The following is a description of a gene set: Mouse Gene Set: OGT_TARGET_GENES from publication Yevshin I, Sharipov R, Kolmykov S, Kondrakhin Y, Kolpakov F (PMID 30445619) Genes containing one or more binding sites for (Ogt) in their promoter regions (TSS -1000,+100 bp) as identified by GTRD version 20.06 ChIP-seq harmonization. species: Mus musculus, and this is the list of marker genes: Egr4, Nup50, Zbtb4, Kif26a, Gm20605, Gm7008, Farsa, Zfp467, Cers6, Natd1, Rtkn, Prps1l3, Fam167a, Srpra, Hspa1l, Tubgcp4, E130311K13Rik, 1110065P20Rik, Phyh, Foxp4, Tmem86a, Tmem74b, Lrp12, Cbarp (NCBI Gene Id 50491), Rpia, Arl4a, Cad, Ldlrad4, Rfx4, Fam178b, Mocs3, Tram1, Ddx17, Clcn2, Bsg, Mrpl2, Gtf2f2, Nlrp5-ps, Tmem123, Trrap, Mms19, 2810004N23Rik, Hmgn1, Ppp1r13l, Dis3l2, Dusp12, Foxf1, mt-Tn, Fhl4, Fcho1, Nat8l, Npl (N-acetylneuraminate pyruvate lyase), Plaat5, Chmp6, Plekhm3, Nol4l, Pacc1, Spopl, Slc25a29, Gatad2a, Asrgl1, Gab1, Crocc, 2300009A05Rik, Anp32b, Tmed4, Smc6, Sh2b3, Itga2b, Cdiptos, Lypd6, Tbrg1, Ndufab1 (NCBI Gene Id 72270), 2810429I04Rik, Trp53bp2, Cxxc5, Gpr68, Ube2g2, Ankrd46, Mapkapk2, Tpt1, A930001C03Rik, Rnf216, Mageb3, Rsrp1, Gpatch11, Lsm14b, Dpp9, Ccdc47, Amotl2, Strip2, Atp6v1f, Bag3, Gm15706, Tug1, Csnk1g1, Adamts20, Stat5a, Ccdc136, Serpine2, Cnppd1, Atp5f1d, Pias3, Tbc1d5, Rrm1, Aktip, Gm10171, Mrps33, Rffl, Depdc7, Nelfe, Celf6, Zfp326, Ptpa (protein phosphatase 2 protein activator), A730035I17Rik, Cpsf4, Gpc4, Ptcd1, Relb, Prkab2, Arhgap35, Chordc1, Gm19569 (predicted gene, 19569), Traf3ip1, Tmem198, Gm27011 (NCBI Gene Id 115486886), Cyb561d1, Crat, Gm9889, Kndc1, Samhd1, Ccnt2, Pik3c2b, Gna15, BC005624, Rere, Dusp5, Tmem237, Tnip1, Plch1, Sar1a, Anapc11, Zfp646, Mtss2, Abcg2, Rapgef6, Wee1, Gm6288 (NCBI Gene Id 635291, predicted gene 6288), Crmp1 (collapsin response mediator protein 1), Ggnbp2, Mapkapk5, Atp5mc3, Wac, Sucla2, Kif7, Lpar3 (lysophosphatidic acid receptor 3), Cpeb3, H19, Naa16, Ubxn7, Atp6v1c1, Denr, Pcgf1, Dbil5, Zfp712, D2hgdh, Sptlc2, Reln, Pgap4, Carhsp1, Mmgt2, Tent2, Ywhae, N4bp3, Kcnn2, Kat6a, Tex264, Tbc1d20, Foxo6, Sp6, Cbx8, Oxnad1, Hectd4, Mipol1, Syncrip, Pkp1, 4930449I04Rik, Thap6, Hikeshi, Cnih4, Alkbh5, Zfp703, Eef2k, Mael, Nup85 (NCBI Gene Id 445007), Atp6v0b, Rasgef1b, Retreg2, Lrrc51, Depdc1b, Hcrtr1, Dnm1l, Nup58 (NCBI Gene Id 71844), Stkld1, Rab35, Eif4e2, Cebpa, Tstd2, Bcl2l13, Plagl2, Ptprz1, Ttc16, Ubxn4, Cbx3, Yjefn3, Brpf3, Uqcc2, Tmem170, Atf6b, Jak1, Iqch, Bola2, Tmem147os, Smim13, Zbtb41, Fhl3, Sgsh, Ddx59, Foxp1, Rap1gds1, Dvl1, Abca3, Sema4c, Xpo7, Mir7071, 5730471H19Rik, Patz1 (NCBI Gene Id 80645), Zcwpw2, Pfkfb2, 2610035F20Rik, Srcap, Trps1, Crebbp, Exo5, Taf11, Dbnl, Map1a, Senp3, Gtf2h5 (general transcription factor IIH, polypeptide 5), Riox2, Ints6, Ptpn4, Phactr4, Exoc6b, Rwdd3, Zfp560, Hcfc2, Fzr1, Anapc2, E130308A19Rik, Crb3, Tunar, Tef, Ankzf1, Rhot1, Zfp382, Spg7, Gm10010, Kcns1, Hlf, Gm17597, Ncbp2as2, Faim, Daglb, Lpar2, Mapk1ip1l (mitogen-activated protein kinase 1 interacting protein 1-like), Dennd2b, Golga4, Snrpa1, Oxsm, Aldh1a2, Ptpn6, Tmx3, Hapln4, Gzf1, Med12, Cisd1, Foxk2, Pdrg1, Col8a2, Pitx3, Dvl3, Thap12 (NCBI Gene Id 72981), Pafah1b1, Gpi1, Dgcr6 (DiGeorge syndrome critical region gene 6), Atg9a (autophagy related 9A), Tfrc, Acot13, Mtmr4, Npcd, Brd2, Dgcr8, Pygo2, Coq5 (NCBI Gene Id 68007), Sh3gl2, Wfdc3, Ptbp3, Lef1, Gm26708, Adarb1, Htt, Gatad2b, Polr3c, Oaf, Txndc9, Atf7ip, Fus, Pdik1l, Gm27242, Mipep, Per3, Noc4l, Paox, Gm20753, Pgls, Ccnq, Sort1, Appl2, Fosl1, Sf1, Nr2f6, Plekhg4, Ccdc160, Pxk, mt-Ta, Cdkn1a, Nfib, Efr3b, Nfs1, Diaph1, Wdr70, Ppp1r2-ps4, Ccdc171, Proca1, Polr2h, 1700041I07Rik, Dnajc9 (NCBI Gene Id 68076), Slc35b4, Abi2, 1700028E10Rik, Gm15040, Iba57, Spen (spen family transcription repressor), n-R5s88, Faf1, Trpc4ap, 1700104B16Rik, Ddx42, Hnrnpr, Dgkz, Arhgef19, Nr1d1, 1110006O24Rik, Pex10, Trerf1, Suco, Hnrnpl, Znrf3, Chd1, Rap1gap, Spice1, Tbc1d9, Uqcc4, mt-Tc, Ubac2, Kctd17, Vax2, Ehmt1, Tubb5, Slc25a30, Mall, Usp43, Cdkn2a, Perp, Bud23, Abca5, Ppp1r3c, Zzef1, Snx8, Anxa2, Grip1, Lgi3, Cnih3, Mob1a, Mtcl3, Pls1, Ilk, Prkag1, Ctdspl2 (CTD small phosphatase like 2), Fignl1, Usp10, Cacna2d2, Rusc1, Smo, Hpca, Psma7, Alg5, Psip1, A430035B10Rik, Ehd2, Rpph1, Usp20, Grina, Crkl, Kiz, Sec24b, Hdgf, Synrg, Tfeb, Prkca, Rbm38, Phf13, Mfsd5, Cdc7, Trappc2b, Stk39, Nynrin, Chst2, G730003C15Rik, Pdgfc (NCBI Gene Id 99691), Ablim1, Dnm3, Pcsk5, Rev1, Tsc22d2, Tgif2, Sgpl1, Mrps23, Rcbtb1, Pithd1, Aqp3, Enc1, Lrrfip1, Atrip, Pdia3, Aldh7a1, Utp14b, Duxf1, Spmap2l, Yeats2, Capn15, Unk, Ogdhl, Mrpl49, Dock7, Dido1 (NCBI Gene Id 329580), Fam98a, Ust, Aip, Cenpt, Slc25a1, Zc3h18, Tjp1, Pik3c2a, Sfi1, Eno1, 4930588K23Rik, Cyb5d2, Gemin4, Slc66a3, Tor1aip1, Plpbp, Lrsam1, Purg, Afg3l2, Ppp2cb, Atg5, Gm15725 (predicted gene 15725), Med17, Atxn7l2, Slc27a4, Tmem59l, Katnbl1, Brd10, Zbtb18, Atp2a3, Ube2d3, Pdgfra, Atg16l2, Traf3, Tbca, Senp7, Cdk4, Znrf1, Pierce1 (piercer of microtubule wall 1), Phc1, Banp, Golm2, Etnk2, Cda, Galnt6, Yif1b, Degs1, Tcf7l1, Gpc1, Zfp791 (NCBI Gene Id 244556), Rad54b, Rtn4rl2, Cant1, Unc50, Tbc1d14, Tent4a, Lncpint, Wrn, Ogfod2, Gm1070, Trim7, Rbm15b, Kdm7a, Plec, Coa5, Mterf3, Rad23b, Sfmbt1, Slc66a2, Tsacc, Ccnf (NCBI Gene Id 12449), Dll3, Rnf44, Parvg, Pds5b, Ptpn9, Lemd1, Rsad1, Eri2, Tpbg, Rnf2, Rchy1, Rnmt, Gadd45g, Ncln (nicalin), Mafk, Fv1, Tmem39b, Bhlhe40, Donson, Dym, Tada2a, Zfp2, Plag1, Ahdc1, Ptpn13, Pex11a, Tgfbrap1, Acss1, Neurl1a, Wwc2, Nlgn2, Pim3, Tut7, Stt3b, Ska3, Ptk2, Garin5a, Sccpdh, Adcy7, Upf1, Osbpl5, Gm12279, 1700064M15Rik, Uso1, Fscn1, Birc5 (NCBI Gene Id 11799), Rgcc, Tspan3, Slc25a3, A730081D07Rik, Cdh2, Sox8, Ldha, Wdhd1, Abca2, Jakmip1, mt-Te, Erc1, Ankrd26, Tsku (tsukushi, small leucine rich proteoglycan), Ociad2, Rbpms, Nup133, Elk4, Ints1, Ptp4a2, Dpf1, Rgl1, Ncoa2, Irf2, Nek2, Xpnpep3, Rras2, Mir762, Ldb1, Kbtbd2, Exosc7, Chtf8, Btg2, Ppfibp1, Tmco1 (transmembrane and coiled-coil domains 1), Mdh2, Hes1, Dolk, Shfl, Pde8a, Clstn2, Pyurf, Flywch1, Tmem104, Khk, 2310001K24Rik, Pdlim7, Hsph1, Morn2, Meak7, Hdac5, Etv6, Arhgap29, Dusp23, Aldh16a1, Ubn1, Cks2, Adgra3, Abcg1, Rarg, Hspbap1, Ptma, Armc6, Gtf2e2, Cdipt, Ripk1, Snx18, Paxbp1, Xpot, Ccdc126, E030042O20Rik, Mapt, Erf, Zfp652os, Ncoa3, Ube2i, Lamb2 (NCBI Gene Id 270417), Fbrsl1, Cspp1, Pus3, Lsm1, Fam210a, Nphp4, Rnf26rt, Sema4b (NCBI Gene Id 20352), Efcc1, Cbx2, Rprd1b, Klf9 (Kruppel-like transcription factor 9), Npas2, Chpf, Pafah1b2, 2500004C02Rik, Bach2, Spcs1, Sycp1, Tmem126b, Gm24641, Tspan9, 2900005J15Rik, Rangap1, 2310026I22Rik, Mir8108, Spaca1, Catsper2, Usp49, Ndc1, Tmem132b (transmembrane protein 132B), Gtf3c4, Khdrbs1, Tamm41, Rassf5, Gm15321, Napb, Polr2f, Opa1, Irf2bpl, F730043M19Rik, Dhx33, Acaa2, Lin28a, Cep126, Fhip1b, Gm5067, Sdf4, Cep152, Cnnm3, Arfrp1, Draxin, Stat1, Endov, Hes6, Ckap2l, Col4a2, Micu1, Gm13162, Atg10, 6330562C20Rik, Supt16, Slco5a1, Bahcc1, Clgn, Sec14l1, Heatr5a (HEAT repeat containing 5A), Gm11889, Gm57488, Tle6, Lmnb1, Tcta, Bbln, Ppp1r2-ps3, Ate1, Kirrel1, AI597479, Braf, Kcnq3, Zic2 (zinc finger protein of the cerebellum 2), Stmn1, 9430015G10Rik, Fosb, Tbkbp1, Map7d1, Ptp4a1, Gm10785, Ccdc117, Dnai1, Clcn6, Dcun1d3, Stx1a, Wbscr25 (NCBI Gene Id 71304, Williams Beuren syndrome chromosome region 25 (human)), Trim25, Zfp786, Zfhx4, Cttn, Mapkapk3, Romo1, Dhx32 (DEAH-box helicase 32 (putative)), Dtl, Srpk1, Cacna1d, Tmem38b, Gm25541, Zfyve27, Psap, Dleu2, Map4k4, Washc4, Bag2, H2az2, Lrrc14, Kcnc1, Psmg2, Tirap, Slc35c1, Ncbp1, Rnf39 (ring finger protein 39), Fanca, Dennd6a, Chchd7, Mad2l2, Slc45a3, Zfp580, Shisa5 (shisa family member 5), Ascc3, Nomo1, Sipa1l1, Ndufa13, Large2 (LARGE xylosyl- and glucuronyltransferase 2), D030047H15Rik, Spo11, AI661453, Tsga10, Sod2, Six2, R3hdm2, Lsm7, Mapk8ip3, Pofut1, F2r, Clptm1l, Btbd6, Atp10d, Leng8, Rev3l (NCBI Gene Id 19714), S1pr1, Gm11475, Ptdss2, Zscan25, Bmf, Ilf3, Fam110a (NCBI Gene Id 99062), Gdf6, Rcc1l, Apeh, Atp13a3, Jag1 (jagged 1), Chmp7, Mfap1a, Slc12a6, Pdpk1, Ago1, Tmem131l, Ttc3, Eif3d, Shank1, Hps5, 9130401M01Rik, St8sia3, Rmdn3, Exosc8 (NCBI Gene Id 69639), Atf5, Hipk2, Mipepos, Haus2, Nup188, Plk5, Ttc4, Nrxn2, Ppargc1b, Kazn, Crtc1, Ezhip, Sltm, Mrpl30, Lrrc75a, Chek1, Ccnl1, Naa20, Tbl2, Rbx1, Pradc1, Derl1, Reep5, Zbtb17, Vsir, Dcaf12 (DDB1 and CUL4 associated factor 12), Wdr93, Azin1, AU040320, Aifm1, Zfp788, Txnrd2, Acsl3, Zfp438, Ppp3r1, Mpc2 (NCBI Gene Id 72048), D430040D24Rik, Gsn, 1700088E04Rik, Crlf3 (NCBI Gene Id 54394), Josd2, Ppp1r12b, Adgrl1, Dazl (NCBI Gene Id 13164), Epha1 (Eph receptor A1), Rell1, Hormad2, Spint1, D130017N08Rik, Nutf2 (nuclear transport factor 2), Thrap3, Ubtd1, Gm14320, Slain1, Slc4a11, Sf3a3, 6430548M08Rik, Nup214, Coq7, Baz2b (NCBI Gene Id 51934), Gm15612, Hspa1b, Dpm1, 1810062O18Rik, Hspbp1, Xkr8, B4galt7, Tle2, Castor1, Gen1, Mir124a-1, Clip1, Pogz, Ell, Ap3m1, Sox12, Fam216a, Mycbp2, Lrrc57, Gm7278, Ctnna1, Zfyve16, Polr3gl, Cnot3, Unc5a, Auts2, Zfp12, Ckmt1, Ccdc71, Lamtor2, Tfb2m, Mtch1, Usp35, Add3, Dcaf5, Lrrc61, Ehbp1l1, Gnai2, Epo, Fam193a, Dbndd1, 4933405D12Rik, Ppp1r16b, Tmie (transmembrane inner ear), Gm13830, Tfdp2, Ube3c, Bin1, Aagab, Vdr (vitamin D (1,25-dihydroxyvitamin D3) receptor), Dnttip1, Pcbp4, Gm7389, Gm8641, Nckipsd, Septin8, Akt2, Gm16062, Hapstr1, Phospho1, Rabep1, Erlin1, Sox21os1, Fbxo24, Ss18l1, Abce1, Gm38250, Ube2l6 (NCBI Gene Id 67250), Ndfip2 (NCBI Gene Id 77152), 4930412M03Rik, Cops5, Cul3, Sh3bp5, Nbeal2, Ss18l2, Gm14966, Surf4, Pex14, Dnaaf9, Lats2, Ppp1r1a (NCBI Gene Id 80526), Htra2, Ubxn6, Pla2g12b, Cpsf6, Stk33, Oma1, Arap2, Gm21985, Mier2, Tmem134, Klc3, Ttc7, Tmem229b, Nsf, 9230116N13Rik, Adpgk, Trim14, Map2k7, Anapc4, Ep400, Ercc6, Osbpl1a, Sprtn, Pgrmc2, Arhgef37, Spag4, Kcnh3, Zfp652, Usp21, Klhl22, Safb2, Aldh18a1 (NCBI Gene Id 69969), C430014B12Rik, Cramp1, Arap1, Mrpl57, Coro6, Cnst, Zfp639, Kctd21, Sgsm3, Mllt11, Gm15587, Egr3, Erich2 (glutamate rich 2), Rfc4, Insr, Ptges3, Ulk1, Hbs1l, Dagla, Ddx25, Git2, Ankrd12, Abcg8, Ebf4, Bcl2l11, Rnf38, Lyrm1, Gm11767, B130046B21Rik, Dlgap3, Scp2, Ppp2ca, Washc1, Rims2, Ash2l, Furin, Nfe2l1, Dyrk1a, Srrd, Slc25a31, Spns2, 5730420D15Rik (NCBI Gene Id 70523), Ypel1, Pik3r1, Ppp2r3a, Senp8, Spag5, Miip, Med9os, Amer3, Slc12a5, Ranbp2, Nphp3, Bicd2, Ppfia1, Ubl3, Tti1, Birc6, Slc6a16, Copg1, Gm11346, Gm14023, Gm4890, Pcbp2, Anapc10, Akap1, Rreb1, Gm16675 (predicted gene, 16675), Zc3h14, Ap1m1, Socs5, Akt3, G630016G05Rik, Rusc2 (RUN and SH3 domain containing 2), Hsp90ab1, Tubgcp3, Rpl12, Dcaf6, Gm2822, Mcur1, Klhl9 (NCBI Gene Id 246693), Atp23, Yars1, Nol11, Mib2 (mindbomb E3 ubiquitin protein ligase 2), Dnmt1, D930048N14Rik, Zfp148, Arpp19, Cdx1, Slc44a3, Emc10, Tulp2, Nolc1 (NCBI Gene Id 70769), Tmem132a, Dhx29, Dusp1, Niban2, Hp1bp3, Nek9, Gm9958, Arl4aos, Timm44, Dyrk1b, Zeb2, Fkbp1b, Lhcgr, Nup153, Pyroxd1, Hmces, Hps6, Lrrc7, Atp1b3, Zfp335os, Abcg5, Gm17135, Tnfsf13os, Trip4, Ccdc9, Marchf7, Nrm, Sod1, Ube2q1, Vamp3 (NCBI Gene Id 320838), Nrf1, Sec31a, Nat9, Zmynd19, Sox5, Kansl1, Ing5, Sdc4, Crtc2, Pdcd6, Galk1, Ythdf2, Jcad, Smad4, 4933440N22Rik, Gm4285, Baiap2, Tgfb3, Gm16001 (NCBI Gene Id 108169069), Pax7, Dsn1, Cilk1, mt-Nd6, Brca2, Pgk1, 4930563E18Rik, Mctp1, Acaca, Syde2, Hoxc6, Mir212, Zfp423, Ap1s1, Psen1, Alyref, Limk2, Dnpep, Itsn1, Sft2d2, Mrps15, Snap91, Usb1, Phax, Mir1938, Rfc1, Tshz3, Morc2a, Mafg, Odad1, Meig1, Uba52, Cdh4, T, Ngly1, Lonp2, Osbpl10, Senp2, Uhrf1, Dipk1b, Hspe1, Safb, Irf2bp1, Cd47, Mtdh, Adamtsl5, Dipk1a (divergent protein kinase domain 1A), Raly, Rabgap1, Gpr137, 6430571L13Rik, Mrpl20, Trp53inp2, 4931415C17Rik, Hsdl1, Nabp2, Ppp1r2, Gm14634, Smarcd3, Flcn, Birc2, Gm24128, Rnf41, 2610307P16Rik, C030047K22Rik, Cdon, Ggnbp1, Cdca2, Ptch2, Yipf5, Cmc2, Cage1, Dhx16, Gorasp2, Pbk, Mbd4, Fitm2, Stag2 (STAG2 cohesin complex component), Ormdl3, Atl2, Gnpat, Strbp, Abca17, Neurog1, Kansl1l, Cdc42se1, Zfp787, Wnt11, Atp6v1b2, Gtf2a1, 4930405A21Rik, Gata5, Eef1g, A230028O05Rik, Cd40, Zdhhc2, Smim14, Heatr5b, Abcc5, Rhod, Selenos, Dna2, Vezf1, Edem2, Ube2n, Ptpru, Snap29, Fbxw8, Atxn7l1, Puf60, Kpna2, Utp3, Cep135, Ssna1, Cav2, Por, Rpp38, Exoc8, Aff4, Cep95, C2cd2, Nfat5, Pthlh, Nfia, Taok3, Wipi2, Slc26a11 (NCBI Gene Id 268512), Srebf2, Wapl, Eif5, Tbx3, Sec24a, Sez6, Srm, Rnf14, Zfp668, Agl, Arhgap27, Pdxk-ps, Celsr1, Ptpn3, Gm20716, Nfe2l2 (nuclear factor, erythroid derived 2, like 2), Mylip, Pak1ip1, Rcan1, Amacr, Nckap5l, 4930589O11Rik, Hsp90aa1, Mphosph8, Tedc1 (tubulin epsilon and delta complex 1), Rptor, Ubc, Gm11772, Mir673 (NCBI Gene Id 751547), Noc2l (NCBI Gene Id 99992), Nf1, Tspoap1, Dlc1, Gan, Ncoa5, Cdyl, Zdhhc3, Casz1, Zfp637, 1810021B22Rik, Pih1d1, Anks1, St13, Socs4, Ttll4, Foxh1, Ttll5, E130307A14Rik, 0610012D04Rik, Sos1, Med14, Ccdc107, mt-Ty, Gpc2, 9330159M07Rik, Tor1aip2 (NCBI Gene Id 98727), Cxxc1 (CXXC finger protein 1), Col4a1, Acot7, Nudt9, Caln1, Tecpr2, Tet3, Ei24, Gbx2, Ctu2 (NCBI Gene Id 66965), Sorl1, Kctd9, Mir7229, Mtmr14, Rimklb, Gm15559, Tmem260, Zfp451, Plaa, Mxi1, Abl1, Ywhaz, Ift122, Mpp3, 0610039K10Rik, Sppl3, Vdac2, Pbx3, 1700025G04Rik, Mtrr, Wdr76, Ier5l, Nudc, Atosa, Cdc34, Lrp1, Rexo5, Lmo7, Rtf1, Gm25794, Dnajb1, Ephb6, Sun2, 2900009J06Rik, Scrib, 4921524J17Rik, Cdc42, Gm26611, Zscan29, Ugdh, Rabl2, Pms2, Mitd1, Tdrd1, Tonsl, Mvd, Rabl3, Atp6v0d1, Erp29, Gnb2, Tax1bp1, Rnf166, Gm15927, Snupn, Ddx27, Mapk14, Hspa8, Glyr1, Cerox1, Mir132 (microRNA 132), mt-Tt, Zranb2, Maml3, Hspa4l, Pou2f1, Crnde, Josd1, Arih1, Skap2, Lcorl, Csrp1, Maneal, Exoc4, Tmem171, Nt5c3b (5'-nucleotidase, cytosolic IIIB), Timm22, Trp53inp1, Lpcat3, Cryzl1, Mir34b, Rcsd1, Gm10472, Phldb2, Xpr1, Emc6, Prdm6, Disp2, Urgcp, Rae1, Heatr3, Pdia5, Gss, Pibf1, Eif4a3, Ncam1, Fbxw2, Adamts5, Cox5a, Snhg11 (NCBI Gene Id 99358), Mknk2, Ntn5, Erg28, Myo9a, 1700101I19Rik, Dlgap4, Rrp8, Noto, Mypop, Fam222b (NCBI Gene Id 319557), Rgs16, Mboat2, Ube2z, Tmem158, Rab34, Med9, Smc5, Ptpn23, Dab2ip, Ndrg3, Styxl1, Pi4ka, Sncb, Tmem116, Plod2, Phlda1 (pleckstrin homology like domain, family A, member 1), Tle1, Parp2, Ipo7, Ccdc172, Gm27042 (predicted gene, 27042), Ipo13, Mlxipl, Tmem147, Katnal1, Pcsk4, Uimc1, Hspb1, Mrpl45, Adcy3, Hspa5, Als2, Crebl2, Naa35, Dmrt3, 1810037I17Rik, Nfkb2, Ltbp4, Dph3, Vamp4, Gm13523, Dbn1, Dffa, Igf1r, Hbp1, Zfp282, Aatf, Kcnh2, 4930539J05Rik, Map3k12, Creld2, Tbc1d8, Capza2, Atp1b1, Stk3, Vax2os, Ykt6, Tvp23b, Alg12 (NCBI Gene Id 223774), Stx11, Prmt7, Gmcl1, Itgb1, Eif5b, B4galnt4, Rab11fip1, Nfix, Azi2, Fam241a, Ift140, Rhoa, Snapin, Slc4a4, Sirpa, Tax1bp3, Fgfr3, Zfp90, Unc80, Aspm (abnormal spindle microtubule assembly), Mthfr, Ccdc92b, 1700007L15Rik, Susd6, Cdan1, Bad, Fau, Agap3, Resf1, Gm16759, Ccnd3, Lrch4, Lima1, Arid3a, Rprd1a, Pdlim5, Litaf, Mob3c, Tnfrsf1a, 1600020E01Rik, St3gal2, 4833418N02Rik (NCBI Gene Id 74597), Pnma8b, Mir378a, Tbc1d15, Borcs5, Mm2pr, Rala, Hspa1a, Nfkbie, Mff, 4732491K20Rik, Reep6, Akap8, Ddx31, Lamp1, Ppp1r15b, Cthrc1, 9530036O11Rik, Dap, Cog6, Recql4, Nedd4, Slc25a20, Mir8092, C2cd4c, Phf24, Dlgap1, Zfand2a, Klf3, Mir675, Ints3, Pacs1, Comt, Mia3, Shoc2, Sgk3, Kcnk12, Zmiz1, Nuak1, Phf21b, Ly6k, Skic2, Fam168b, Thy1, Ubqln1, Gm15564, Uspl1, Usp12, 4632404H12Rik, Dennd1a, Calm1, Uck1, Macrod2, Elfn2, Aebp2, Stag3, Meis2, Snrnp48 (small nuclear ribonucleoprotein 48 (U11/U12)), Lats1, Pcbp1, Pigp, Ago4, Six5, Umps, Nsd3, Gm9922, Trabd, Kras (Kirsten rat sarcoma viral oncogene homolog), Ncs1, Gstz1, 1700022N22Rik, Cops8, Phldb1, Gm19744, 1700120C14Rik, Gm13610, Gm27017, Mpc1, Rgs7, Snapc2, Ddx51, Coq8b, Clu, Cfap97, Hivep2, BC004004, Gm49405, Rnf115, Camk1d, Klf13, Arid3b, Pcmt1, Lrrc1, Arhgef26, Slc7a6os, Katna1, Oard1, Sec14l2, Rbms1, Chic1, Ifrd2, Tmcc3, 4930537H20Rik, Gm5100, Cited2 (NCBI Gene Id 17684), Chaserr, Nptn, Dynll1, Unc5b, Tdp2, Ddit3, Kcnab2, C1qbp, Camk1, Gm10517, 4930404H24Rik, Rnf111, Mfn1, C230096K16Rik, Sall2, Socs2, Vars1, Slc35e2, Fzd3, Usp32, Tnpo2 (transportin 2 (importin 3, karyopherin beta 2b)), Kifc1, Mtres1, Rgs8, Gpbp1, Sntb2, Ints7, Ubqln4, Myo10, Cd63, Dnajc14, Msl2, Sys1, Epb41l5, D030056L22Rik, Hps4, Pabpc1, Kdm1a, Edem1, Foxo3, Lrp2, Ankrd17, Akip1, Fbxo9, Gpd1l, Ost4, Tcf7l2, Dpep3, Ppp4r2, Cmtr1, Zfp292, Itm2c, Zfpl1, Henmt1, Dis3, Gm10863, Edn3, Glg1, Rab43 (RAB43, member RAS oncogene family), Hnrnpa2b1, Zfp629, Gm26590, Ing1, Map2, Chuk, Pamr1, Gne, Tsn, Tmem127, Peds1, Uqcrc1, Tmem167b, Erc2 (ELKS/RAB6-interacting/CAST family member 2), Map6 (NCBI Gene Id 17760), Wdr45b, Zfp518a, Trmt1l, Med11, Cpne9, Xpo5, Lamtor3, Ddx5, Wdr82, Pelp1, Rab1b, Mmaa, Smarca4, Rgs22, C1ql1, Srrt, Ppp1cb, Camsap2, C1ql4, Cbx6, Rpl34, Yrdc, Sugp2, Bnc2, Cct4, Aph1c, Zbtb7a, Tapbp, Kpnb1, Agtpbp1, Dnaaf1, Naa25, N4bp2l1, Stam2, Afap1, Emb, Pan3, Ubald2, H2-Q6, Mtrex, Rgl2, Srrm2, 4930430O22Rik, Abhd3, Prkar1a, Tada1, Gpatch2l, Zbtb9, Klhdc8b, Gm13034, Phf23, Cmip, Bag4, Gm13421, Clpx, Cdh10, Bid (NCBI Gene Id 72579), Ccdc158, Zfand3, Nadk, Tbrg4, Nbeal1, Trnau1ap, 1700012B09Rik, Sox21, Hspd1, Lzts3, Gfpt1, Osbp2, Disp3, Ciao1, Plcg1, A730013G03Rik, Aftph, Ube2k, Nectin3, Gm16576, Jade3, Gga2, Zbtb21, Max, Gpn3, Cdk6, Cinp, Pdlim3, Vipas39, Rab3gap2, Pwwp2a, Mir207, Ebpl, Dnaja1, Radil, Gm19412, Ptprk, Sars1, Adad1, 4930592C13Rik, Snap23, Fgfrl1, Plpp2, Abtb1, Cxxc4, Armh3, Dcun1d4, Mcrip2, Uba6, Gm12841, Msantd3, Itpripl2, Utp4, Lonrf2, Fgf9, Scrt1, Bcl7c, Csk, Copb1, Ncbp2, Smim29, Sptb, Thop1, Pitx1, Slx1b, Pdxdc1, Fendrr, Arhgef40, Svop, Atp6v1h, Chst12 (NCBI Gene Id 59031), Klhl10, Snx7, Ube2g1 (NCBI Gene Id 67128), Phlpp1, Tesk1 (testis specific protein kinase 1), Als2cl, Gm12059, P4ha1, Ctnnb1, Nup93, Prm2, Fam219a, Zfp131, Fblim1, Htra1, Ksr2, Snn, 1810041H14Rik, Rasd2, Swt1, Prkag2, Sde2, Hebp1, Serac1, Mxd3, Pgm2l1, Ahsa1, Pik3cd, Gtf2e1, 8030474K03Rik (RIKEN cDNA 8030474K03 gene), Dync2i2, Kif20b, Slc35f2, Arpc2, 9430091E24Rik, Fkbp4, Rab2a (NCBI Gene Id 93773), Kpna1, Clasrp, Mcoln1, Csnk1a1, Lrfn5, Cers2, Ubb, Wdsub1, Larp1, Brk1, Ncdn, Erbb3, Srsf1, Pigv, Tut4, Sema6a, Agap1, Gtf2h1, Atp8b2, 9130017K11Rik, Serbp1, A730017L22Rik, Apbb2, Trp53, Cpped1, Tdrd9, Sun1, Fmo4, Mycbp (MYC binding protein), Cdca5, Apc, Ankrd37, Setx (senataxin), Fank1, Med26, Pomt1, Zbed4, Cbx4, Gm10069, Arfgap3 (NCBI Gene Id 75390), Polh, Acer2, Mir34c, Atrn, Pdzrn3, Msx1, Ppl, Rny3, Suds3, Fgd4 (NCBI Gene Id 320417), B3galt6, B230219D22Rik, Inafm2, Tollip, Cct3, Actn4, B4galt2 (UDP-Gal:betaGlcNAc beta 1,4- galactosyltransferase, polypeptide 2), Tc2n, Slc35a1, Exoc5, Zgpat, Dhrs13, Senp5, Epas1, Pik3r3, Tex30, Dennd2a, Rbm22, Saysd1, 9530068E07Rik, Dnajc30, Gsap, Krt72, Stip1, Mcrs1, Slc6a7, Fastkd3, Rnf126, Ano1, Mir6236 (microRNA 6236), Dstyk, Papola, Glcci1, Ap5m1, Nfya, Get4, A930004D18Rik, Panx1